The following is a description of a gene set: species: Homo sapiens Catalysis of the reactions: ATP + protein serine = ADP + protein serine phosphate, and ATP + protein threonine = ADP + protein threonine phosphate. Human Gene Set: GOMF_PROTEIN_SERINE_THREONINE_KINASE_ACTIVITY, and this is the list of marker genes: MAP4K5, WNK1 (WNK lysine deficient protein kinase 1), MAP3K19, CAMKK2, CCNB2, SYK (spleen associated tyrosine kinase), MAP4K1, SGK3, HUNK, TTBK2, KSR2, NEK3, MLST8, MOK (MOK protein kinase), CDK14, ATM, MAPKAPK3, STKLD1, PPP5C, RAF1, MNAT1, ALS2, ALPK3, GRK2, CAMK2A, PAK1, MAP3K3, PDK2, ATR, CSNK1G2, ADIPOQ, STK31 (serine/threonine kinase 31), PIK3CA, CDK20, BCKDK, IKBKE, CSNK2A2, WNK3, DCLK3, CNPPD1, ATAD3A, RSKR, SBK1 (NCBI Gene Id 388228), C8orf44-SGK3, PDK4, SRPK2, CCND3, CCNA2, CCNI2, PBK, PAK2, BMPR1B, SPEG, MAP3K14, HSPB1, PHKA1, MAK, MASTL, TPX2, DEPTOR, SGK2, MAPK15, RIPK4, AKT2, CDK7, CDKN2B, DGKQ, DYRK2, GRK5, MAP3K7, PRKD3, LTBP1, TNK2, MOB1B, CDKN2C, ANKK1, DCLK1, MAPK4, FASTK, MTCP1 (NCBI Gene Id 4515), LRRK2, CCNG2 (cyclin G2), MACROH2A1, LATS1, CDKN2A, PGK1, PDIK1L, STRADB, STK17A, BCR, CAMK4, IKBKB, RPS6KA1, TAF1L, RPS6KA3, TGFB1 (transforming growth factor beta 1), CDK19, ACVR1C, TAF1, STK10, STK4, NRBP1, TESK2, ALPK1, BRSK1, NRBP2, PRKCB, GRK3, NEK2, VRK1, CAMK2G, PRKAB2, PASK, CCND2, DAPK1, CCNA1, DAZAP2, PAK3, ALPK2, CKS2, AKT1S1, NEK8, STK25, ULK3, CCNO, PINK1, AAK1, HJV, MAPRE3, TNKS1BP1, CDKL2, LIMK1, MAP2K6, CLK2, AKT3, CDKN2D, GSK3A, PRKAG2, CDK5R2, ACSL1, OXSR1, STRADA, CAMK1G, PRKDC, NRK, RPS6KB2, MAST4, CIT, CLK1, KSR1, LTF, MAP3K10, GRK6, CDK16, TTN, PIM2, CCNH, MAST1, MARK2, CHEK2, SBK3, PRKX, CDK6, PRKAR1A, CDK8, LRP6, ATG13 (NCBI Gene Id 9776), PIKFYVE, MAST2 (microtubule associated serine/threonine kinase 2), HIPK1, RPS6KL1, BMP2K, NEK10, MINK1, ETAA1, VRK2, DYRK1B, CAMK2B, PLK2, TRPM7, STK38, STK36, CSNK2A3, MSTN, STK19, PDK3, HMGB1, CILK1, ITPKA, NIM1K, IRGM, RPS6KC1, ILK, CDK11A, LATS2, HIPK2, MAP3K15, DCAF1, BMP4, MYLK2, ACVR1B, CDKL3, ADCK5 (NCBI Gene Id 203054), BMPR1A, MELK, CCND1, PPP1R1B, NEK5, MAP3K5, TRIB3, RICTOR, MAPK9, PRKAG1, TGFBR2, PRKCE, TGFBR3, WNK2, CCNT2, CSNK2B, ACVR2B, ERN1, TESK1, IRAK4, CDKN1A, DBF4B, MAP3K9, IQGAP1, IRAK1, ULK2, BRD3, CCNK, PARP8, PRKCG, CDC42BPB, BMP2, CHEK1, CCDC88A, ELP4, PLK4, CAMK2D, TSSK1B, PRKD1, PARP16, MAP3K1, SPRED1, CDK11B, RPS6KA5, CCNE2, CLK4, DCLK2, BRD2, PRP4K, STK35, SIK1, HSPA5, TNIK, CIB1 (calcium and integrin binding 1), PTK2B, PLK1, CDC42BPA, SLK (NCBI Gene Id 9748), TAOK1, YWHAG, CSNK1A1, BMP7 (bone morphogenetic protein 7), GDF10, NEK11, CAMK2N1 (calcium/calmodulin dependent protein kinase II inhibitor 1), VRK3, CDKL4, RIPK1, TSSK3, CCNB3, PKMYT1, STK16 (serine/threonine kinase 16), GCN1, PIM3, PRKCA, BUB1B, PNCK, SAMD15, CDK12, DYRK1A, MARK3, DELE1 (NCBI Gene Id 9812), PPM1D, STK33, TLK1, MYLK4, CDC42BPG, MAP3K6, PRKAA2, CDK5R1, MAP3K13, AXIN1, RPS6KA6, CAB39L, CASK, GRK7, KAT2B, OBSCN, ELP3, CDK2, PIK3R4, HTRA2, MOS, BUB1, CAMK2N2, RIOK2, MAPK3 (NCBI Gene Id 5595), HIPK4, PRKAG3, MOB1A, EIF2AK1, PRKACG, FAM20C, PDK1, LIMK2, PKIA, SMG1, CCNL1, CKS1B, MKNK1, MAPK1 (mitogen-activated protein kinase 1), CDK18, STK24, RACK1, PRKACB, LTBP4, LRRK1, MYO3A, TSSK2, ULK4, EEF2K, MAP3K21, AMHR2 (NCBI Gene Id 269), PRKY, MYLK, CCNQ, AKT1, CSNK1A1L, ACVRL1, TBK1, PRKCD, ERN2 (NCBI Gene Id 388226), CAMK1D, TRIO, TGFBR1, MLKL, CSNK1E, DBF4, PIK3CG, TOPBP1, INCA1, NUAK1, MTOR (mechanistic target of rapamycin kinase), PKN2, DAPK3, ADCK2, GAK, PREX1, DSTYK, MAP3K11, EIF2AK2, DYRK3, DYRK4, ULK1, RIOK1 (RIO kinase 1), TAB1, MAPKAPK2, TCL1A, PPEF2, KALRN, MAP4K4, UHMK1, CCNT1, SRPK3, CCNE1, PLK3, CDK9, SMO, MAP2K5, CXCL10, PKIB, FERMT2, NEK7, CDK15, TOP1, CSNK1G3, PRKG2, AURKB, PREX2, STK11, CDK3, CDK5, WNK4, PRKAA1 (NCBI Gene Id 5562), DMPK, CD40LG (CD40 ligand), MAPK6, SNRK, STK38L, SFN, SRPK1, PRKCH, MAPK13, PYDC1, CSNK2A1, EGFR, PKN3, CSNK1G1, BRD4, CDKN1C, CHUK, CAMKK1, BRSK2, CSNK1D (NCBI Gene Id 1453), EIF2AK3, EIF2AK4, MKNK2, MAPK10, ACVR1, CLK3, MAP3K8, ROCK1, STK32B, PAK6, PRKAR2A, CAMKV, PSKH2, MAP2K7, RIPK3, RAD50, DDX3X, NEK6, HIPK3, MAPK11, CCNJL, CDK13, MAP3K20, FAM20A, MAP2K2, CIITA, TP53RK, PAK4, SIK3, CCNP, MAPK14, STK17B, PRKCQ, MAST3, CDC7, NEK9 (NCBI Gene Id 91754), SAV1, SPRY2, GRK4, TSSK4, STK26, TTBK1, PHKG2, CCNC, RPS6KA4, STK32C, PRKAR1B, CCNY, RHEB (NCBI Gene Id 6009), PARP6, MAPK8, GSTP1, MAP4K2, TLK2, NEK1, CAMK1, BMPR2, SIK2, PRKCI, MAP3K12, PRKCZ, PRKAR2B, PSKH1, CCNJ, MYLK3 (NCBI Gene Id 91807), CDK17, PRKACA, TNNI3K, AATK, CCNB1, CCNF, MARK4, INKA2, AURKC, STK3, DAPK2, MAPKAPK5, CAB39, PHKA2 (NCBI Gene Id 5256), AURKA, TSSK6, MAP2K1, MARK1, TRPM6, TTK, ROCK2, PHKG1, LMTK2, CDK10, PIM1, RIPK2, CDKL5, MAPK12, RPTOR, CDKL1, CDK1 (cyclin dependent kinase 1), CALM2, GRK1, INKA1, NBN, MAP2K4, GSK3B, RPS6KB1, TGFBR3L, DAB2IP, BRAF, CDKN1B, RIOK3, IGF2, PAK5, PRKD2, SLC27A1, HTATIP2, HEXIM2, CDK4, PKM (pyruvate kinase M1/2), ARAF, CALM1, BRDT, CCNI, LMTK3, STK40, GDF2, CPNE3, MAPK7, SPRED2, MAP4K3, NEK4 (NCBI Gene Id 8380), CASP3, TCL1B, ADCK1, STK32A, IRAK3, MYO3B, NUAK2, TAOK2, NLK, HEXIM1, TAOK3, HASPIN, CCNG1, CCNL2, ANKRD42, SOSTDC1, PKN1, PRKG1, SGK1, MAP3K4, PKIG, SBK2, CALM3, RPS6KA2, STK39, MAP2K3, ACVR2A, PDPK1, ATP23, MAP3K2